The following is a description of a gene set: Mouse Gene Set: GOBP_PROTEIN_LOCALIZATION_TO_LYSOSOME studied in species Mus musculus A process in which a protein is transported to, or maintained in, a location within a lysosome., and this is the list of marker genes: Lmbrd1, Sorl1, Ap4m1, Mfsd1, Vps53, Ndp, Gpr137b (G protein-coupled receptor 137B), Nedd4, Pik3c3, Ap3d1, Snx16, Atg14, Ap3b1, Rtn4 (NCBI Gene Id 68585), Akt1, Gga3, Szt2, Lamp2, Kptn, Lamtor1, Lamtor5, Rock2, Vps4a, Pik3r4, Atp13a2, Meak7, Gcc2, Cd81, Laptm5, Clu (NCBI Gene Id 28201), Lyset, Hspa8, Rragc, Becn1, M6pr, Gnptab, Scarb2, Lhcgr, Ncoa4, Sort1, Zfyve16, Rab7, Glmp (NCBI Gene Id 80390), Kics2, Rraga, Sh3bp4, Hgs (HGF-regulated tyrosine kinase substrate), Vps54 (NCBI Gene Id 245944), Lamtor4